Given this list of marker genes STRC (NCBI Gene Id 1708), SIX4, LRIG3, NEUROG1, SLITRK6, HPN, CDH23, OSR1, CHRNA10, SCRIB, WDPCP, TSHZ1, COL11A1, USH1G, FGF10, CHRNA9, NOG, NTN1, WNT3A, TCAP, FGFR1, FOXG1, INSIG2, EYA1, GRXCR2, TBX2, EDN1, WDR19, TWIST1 (NCBI Gene Id 7967), NECTIN3, MYO7A, TTC39C (tetratricopeptide repeat domain 39C), CLRN1, MYO6, EPHB2, FGFR2, NAGLU, ITGA8, MYC, RPL38, NIPBL, NECTIN1, MAPK3, ZEB1, GATA2, NKX3-2, DVL2, NHERF1, GRXCR1, LRIG1, TRIOBP, PAX8 (paired box 8), DLX5 (NCBI Gene Id 80275), SOX9, WHRN, ATOH1 (atonal bHLH transcription factor 1), DLX6, VANGL2, TBX1, STOX1 (storkhead box 1), MSX1, MYO15A, POU4F3, POU3F4, FGF8, SPARC, NR4A3, GATA3, DCANP1, USH1C, OSR2, TIFAB, WNT5A, TFAP2A, WNT1, HOXA1, MYO3B, SIX2, TBX18, BLOC1S5, PAX2, PROX1, TECTA, FOXI1, PDZD7, HMX3, SEC24B, BCR, ANKRD24, PRRX1, OTOP1, SIX1, SLC44A4, OTX1, PLS1, FGF9, SPRY2, ALDH1A3, GBX2, CTHRC1, COL2A1, FZD6, INSIG1, TPRN, ATP6V1B1, LHFPL5, MYO3A, FRZB, CHD7, KCNQ4, EDNRA, GJB6, ATP8A2, ZIC1, GRHL3, HESX1, HOXA2, FZD2, GSC, REST, DVL1, TBX3, SOBP, RAC1, HMX2, SOD1, ZIC3, TMIE, MAFB, PTK7, PRKRA, CLRN2, CEP290, MAPK1, FZD3, KCNQ1, here is a description of the gene set: The process in which the anatomical structures of the ear are generated and organized. The ear is the sense organ in vertebrates that is specialized for the detection of sound, and the maintenance of balance. Includes the outer ear and middle ear, which collect and transmit sound waves; and the inner ear, which contains the organs of balance and (except in fish) hearing. Also includes the pinna, the visible part of the outer ear, present in some mammals. species: Homo sapiens Human Gene Set: GOBP_EAR_MORPHOGENESIS